Given this list of marker genes GPR155, RPAIN, COG5, RELA, BTAF1, MPZL3, GTPBP4, TBCEL, ZNF550, NOP10, LINC02693, P3H1, CCDC90B, CRYBG2, UBALD1, USP9X, SNAI3-AS1, MPC1, ELOVL4, ZNF691, TMEM208, TPRKB, THEM6, GJA3, RFC2, SNAPIN, ZIK1, PURB, RNF4, IGSF9B, SNRNP48, POU2F1, ZNF252P-AS1, GTF3C5, PCGF3, ADAM9, COQ10A, KLHL25, PAQR8 (NCBI Gene Id 85315), SAR1B, MRS2, SNAPC2, CDKN2B, ZNF267, CHCHD7, PAPOLG, CENPE, PLS1, COQ5, ISL2, LUZP1, TTC3, FAM76A, RANBP2, DDI2, TFEB, APEH, SLC2A6, POC5, TRIM4, AKAP17A, GPR108, INPP5B, RIOK2, CFAP184, CEP104, ENGASE, RPRD1A, URB1, MYH3, UQCRC2, RNF146, API5, HEY1, SLC31A2, CCDC77, ZFAND6, ASF1A, TRAPPC9, RAB7A, MYO9A, TASP1, RIOK3, MRPS10 (mitochondrial ribosomal protein S10), LAPTM4A, RPL36, TRPV1, SKP1, H4C3, MFSD14B, TTPAL, LSR, ITSN1, ATP6AP1, HOMER1, CLBA1, RAB36, PILRB, RELB, TMEM127, CYP2U1, TXLNG, SERAC1, BPNT2, SSH1, DALRD3, LMAN2, MED23, INSIG2, RNF181 (NCBI Gene Id 51255), PACSIN2, PDE6D, THOC1, ATP5MC3, KCTD13, COPS7B, DUSP23, UCN, MAD2L2, TNKS, MARS2, MIPEP, GIGYF2, SYNGR2, ENSG00000215022, DCLRE1A, UBL5, JAM3, ING5, AHCYL1, ATP6V0E1, H2AC6, COX6A1, PIP5K1C, FLVCR1, CAPN7, GON7 (GON7 subunit of KEOPS complex), STRBP, SNIP1, HSD17B12, CEP85, ARL3, SMIM8, MAPK14 (NCBI Gene Id 1432), TRAF6, EMSY, ATXN1L, EMC1, PYGO2, TEX261, SEC16A, FBXW9, TBC1D8, WASHC4, WIPI2, PSMD11, TFAM, EXT1, DBT (dihydrolipoamide branched chain transacylase E2), ZNF654, NAMPT, INTS2 (integrator complex subunit 2), MTFR2, EBNA1BP2, TWNK, TM2D3, CHP1, CSNK2A2, AIG1, TEAD1, BRD8, CXCL16, RHBDD3, CCT6A, YAP1, BFAR, DPY19L2P2, STK38L, DCLRE1B, TSR1, POLE2, METTL23, ABTB3, DLD, WDR89, SYNJ1, TMEM11, TMEM120B, MRPL35, RNF26, WBP11, PIP4K2C, SIVA1, NLGN2, HPCAL1, SRP54, NELFE, here is a description of the gene set: Th1 and Th2 cells arise from a common precursor cell in response to triggering through the TCR and cytokine receptors for IL-12 or IL-4. This leads to activation of complex signaling pathways, which are not known in detail. Disturbances in the balance between type 1 and type 2 responses can lead to certain immune-mediated diseases. Thus, it is important to understand how Th1 and Th2 cells are generated. To clarify the mechanisms as to how IL-12 and IL-4 induce Th1 and Th2 differentiation and how TGF-beta can inhibit this process, we have used oligonucleotide arrays to examine the early polarization of Th1 and Th2 cells in the presence and absence of TGF-beta after 0, 2, 6 and 48 hours of polarization. studied in species Homo sapiens Genes down-regulated in CD4 T cells activated by anti-CD3 and anti-CD28: TGFB1 and IL4 (6h) versus untreated (6h). Human Gene Set: GSE2770_TGFB_AND_IL4_ACT_VS_ACT_CD4_TCELL_6H_DN from publication Lund R, Aittokallio T, Nevalainen O, Lahesmaa R (PMID 14607935)